Given this list of marker genes AP2B1, MYLIP, AP2A1, NR1H2, VLDLR, RPS27A, UBC (ubiquitin C), CLTA, AP2A2, NR1H3, AP2S1, AP2M1, CLTC, UBB, UBA52, PCSK9, here is a description of the gene set: Reactome Pathway: VLDLR internalisation and degradation part of: Plasma lipoprotein clearance The steps involved in proprotein convertase PCSK9-induced degradation of VLDLR are described here. The rate of this catabolic process plays a clinically significant role in determining the efficiency of lipoprotein clearance from the blood. species: Homo sapiens